Given this list of marker genes DCTN1, CCDC68, KIF2A, CNTRL, CEP128, CEP170, NIN, ODF2, CCDC61, CCDC120, here is a description of the gene set: A protein complex which assembles on the mother centriole during cilium formation, adjacent and proximal to a centriolar distal appendage. In human, it contains ODF2, CNTRL, NIN, CCDC120c and CCDC68. Human Gene Set: GOCC_CENTRIOLAR_SUBDISTAL_APPENDAGE species: Homo sapiens